The following is a description of a gene set: studied in species Homo sapiens Mouse CD8+ T cells affected by ID3 (Inhibitor of DNA binding 3) display patterns of gene expression suggesting enhanced persistance and survival. In this study, we identified genes differentially expressed between ID32a transduced and mock transduced, and ID32a knockout and wild type mouse CD8+ T cells. Most prominent functions of differentially expressed genes include DNA replication-associated repair, maintenance of chromosome stability and mitotic cell divison machinery. Overall, these data suggest that ID3 acts in favor of maintained survival in CD8+ mouse T cells. Genes down-regulated in CD8 T cells: ID3 knockout versus wildtype. from publication Ji Y, Pos Z, Rao M, Klebanoff CA, Yu Z, Sukumar M, Reger RN, Palmer DC, Borman ZA, Muranski P, Wang E, Schrump DS, Marincola FM, Restifo NP, Gattinoni L (PMID 22057288) Human Gene Set: GSE23568_ID3_KO_VS_WT_CD8_TCELL_DN, and this is the list of marker genes: ATF6, FCRLA, HS3ST1, PPP3CA, CSK, PDXK, NCF4, IGLC7, EVI5, TXNDC16, PRKCE, P2RX4, C1R, CD81, PDE1C, SIPA1, HHEX, PPP3CC, CDT1, SMAGP, PKIG, PKIB, TRAPPC5, PML (NCBI Gene Id 5371), LAT2, NAPB, RHOQ, PLCG2, MBD4, RBM4B, EIF2AK3, MTPN, TCF4, POLD1, SYPL1 (NCBI Gene Id 6856), CTSC, CDIP1, SLC4A7, ANXA1, UGP2, SLC16A7, SNX9, MYO5A, NAPSA, IRF5 (NCBI Gene Id 84729), CA2, NFE2L1, POLR1H, IRAG2, CTSZ, BLNK, MARCKS, GM2A, KIAA0930, NEDD4, MCOLN2, PRKCD, JARID2, STRBP (NCBI Gene Id 55342), ZC3H12C, SCD, TEC, SNX2, XBP1, ZNF282, KCTD12, DYNLT2, DDX41, CD37, MRPL45 (mitochondrial ribosomal protein L45), C9orf85, HLA-DRB1, CXXC5, ARHGAP21, FUCA1, ZDHHC14, ADAM9, PRSS23, MYADM, SLC25A53, SNX5, CHEK2, CTSH, CD40, SLC7A7, CNN3, HIP1R, CMTM7, CD79B, PLD4, IRF4, CLCN5, LY86, PTP4A3 (NCBI Gene Id 11156), SLC31A1, ATP6V0B, FANCM, BCKDHA, ERO1B, PSPC1 (NCBI Gene Id 55269), PBX3, CARHSP1, E2F1, MIF4GD, INPP5A, ADRB2, CNR2, LYL1, BTK, HLA-DOA, LGMN, IFI30, PAFAH1B3, CD22, PTPN6, RASD1, MS4A1, TPD52, MYO1E, EIF2AK4, LY6D, OSBPL5, HLA-DMB, CXCR4, SMARCD2, ABCA1, SRPK3, TRMT2A, EBF1, GPD2 (NCBI Gene Id 2820), PER2, TTC4, CD83, CPSF2, DPP7, PLAC8, MEF2C, PLBD1, CCR6, CIITA, PLA2G7, RBM26, IL4I1, CD19, CD93, TOR3A, SH2B3, RYR1, CEP89, RALGPS2, CD2AP, PARP1, ELL2, SIPA1L2 (NCBI Gene Id 57568), HLA-DOB (major histocompatibility complex, class II, DO beta), VCL, NECAP2, IRF8, BCL2L2, RASGRP2, SOWAHC, CBFA2T3, GAD1, MRPS22, HLA-DQA1, FCGR2B, RAB5C, SYK, BMP2K, IQGAP1, NICN1, TMOD3, GPR137B, APOE, FCER2, GGA2, MAP3K8, CD72, LYN, NCF2, HCK, RTL6, IGHM, TPST1, IL10RA, SPIB, SORL1, CXCR5, BLK, LMO2, MX1, SERPINB1, SLC30A5, POU2AF1, ALDH2, LIMD1, PXK, CLIC4, CR2, NUCB2